The following is a description of a gene set: from publication Elo LL, Järvenpää H, Tuomela S, Raghav S, Ahlfors H, Laurila K, Gupta B, Lund RJ, Tahvanainen J, Hawkins RD, Oresic M, Lähdesmäki H, Rasool O, Rao KV, Aittokallio T, Lahesmaa R (PMID 20620947) species: Homo sapiens Genes up-regulated in comparison of untreated CD4 T cells at 0 h versus the cells treated with IL4 and anti-IL12 at 2 h. The aim of this dataset was to study in detail the transcription kinetics initiated by cytokine IL-4 in early differentiation of Th2 cells. Human Gene Set: GSE17974_CTRL_VS_ACT_IL4_AND_ANTI_IL12_2H_CD4_TCELL_UP, and this is the list of marker genes: DLG3, PSTK, ADPRM, ENSG00000280119, IRF1, CD4 (NCBI Gene Id 920), PPP1R7, GPD1L, FAM78A, NRGN, SLC35G1, IRS2, HHATL, LINC00896, UST-AS1, PGLS, TIGD1, TDRKH, SPG21, GABBR1, MCOLN1, AP3S2, PSTPIP1, MAP3K12, ANKS6, CCDC85B, WASF2, ITGB2, TAFAZZIN, DENND5A, ARRB1, SOX14, CNPY4, NEU4, TPI1, P2RX5, IL11RA, PGAP3, SMCR5, SLC35E2B, GPRASP2, TNFSF8, NTAQ1, DNAJC4, KLHL15, ANKRD10, REPIN1, G0S2, ZMIZ1, ABCC5, TMIGD2 (NCBI Gene Id 126259), KLF11, APRG1, FAM200B, EPHX2, PGAP2, SC5D, MYO1G, THADA, ARRDC3, EPS8L2 (EPS8 signaling adaptor L2), RP9P, ZBTB8B, XXYLT1, GADD45A, DUSP1, GMPS, WDR19, HEMK1, FOS, ZNF101, UBASH3B, ITGAL, SPO11, SLC16A5, ANKRD39, OR12D2, CITED2, TAGLN2, PRKCE, ADARB1, BLVRA, OTUD1 (OTU deubiquitinase 1), GPR153, UBE2Q2P13, WAS, ENTREP3, JUN, PIEZO1, KIFC2, FLOT2, CREB3L2, TCEA3, NFKBIZ, HAR1A, CDCA7, DDIT4, ENC1, VPS26B, STK10, RCSD1, AREG, PCNT, MORC2-AS1, CARINH, PRKCZ, R3HDM2, FANCC, TOB1, MRPL1, IL36RN, PTK2B, TRADD (TNFRSF1A associated via death domain), ALKBH7, LDB2, SUMF2 (NCBI Gene Id 25870), CORO1B, MTFR1L (NCBI Gene Id 56181), MAFF (NCBI Gene Id 23764), FBXL16, NUP210 (NCBI Gene Id 79985), SLC2A3, RAP1GAP2, LY6E, ZNF844, ERP27, PPIP5K1, UBE2G2, PDE4B, INSL5, PTP4A1, EIF4G3, ADGRE1, TSPAN17, ATP6V0E2, RGS2, SNN (stannin), POLR3GL, H1-10, LYRM9, KLF4, TYSND1, ITGA6, GALNS, SIK1, NMRK1, SAMHD1, BIN1, CNBD2, FAM168A, TRABD2A, EVL, SNX29, ROGDI, MRPL40, TSC22D1, BCL7A, TARBP1, ZFAND2A, RPS6KC1, RASGRF2, SOCS3, MEF2D, FHIT, FAM111A, SYTL4, EBPL, FAM24B, PCIF1, PCNX2, ZDHHC11, NUDT19, SLC10A7, STK16, ZNF34, DHRS7, RHEBL1, ACAP1, PIM1, VNN2, PHKB, OXNAD1, RGS1, MMD (monocyte to macrophage differentiation associated), GSAP (NCBI Gene Id 54103), DTD1, CD52, MAPKAP1, ATP2B1-AS1, LILRB2, GAL3ST4, PPP3CC, NIT2